The following is a description of a gene set: Human Gene Set: GOBP_SALIVARY_GLAND_DEVELOPMENT studied in species Homo sapiens The process whose specific outcome is the progression of the salivary gland over time, from its formation to the mature structure. Salivary glands include any of the saliva-secreting exocrine glands of the oral cavity., and this is the list of marker genes: PAX6, ESRP2, FGF8, PLXND1 (plexin D1), SNAI2, TNF, FGF10, FGF7, LAMA1, CLCN2, XBP1, DAG1, EGFR, ASCL3, NFIB, HGF, TGM2, PLXNA1, TWSG1, BTBD7, TGFB1, LAMA5, TFCP2L1, NTN4, SHH, NKX3-1, PDGFA, BMP7 (NCBI Gene Id 655), TGFB3, SEMA3C, NRP1, POLB (DNA polymerase beta), EDAR, FGFR1, TGFB2, EDA, FGFR2